The following is a description of a gene set: Sle2c1 is an NZM2410-derived lupus susceptibility locus that induces an expansion of the B1a cell compartment. B1a cells have a repertoire enriched for autoreactivity, and an expansion of this B cell subset occurs in several mouse models of lupus. Here we showed that expression of Sle2c1 enhances NZB cellular phenotypes that have been associated with autoimmune pathogenesis. A combination of genetic mapping and candidate gene analysis presents Cdkn2c, a gene encoding for cyclin kinase inhibitor p18INK4c (p18), as the top candidate gene for inducing the Slec2c1 associated expansion of B1a cells. A novel SNP in the Cdkn2c promoter is associated with a significantly reduced Cdkn2c expression in the splenic B cells and B1a cells from Sle2c1-carrying mice, which leads to defective G1 cell cycle arrest in splenic B cells and increased proliferation of Pc B1a cells. As cell cycle is differentially regulated in B1a and B2 cells, these results suggest that Cdkn2c play a critical role in B1a cell self renewal, and that its impaired expression leads to an accumulation of these cells with high autoreactive potential. Genes up-regulated in B lymphocytes from: peritoneal cavity versus spleen. species: Homo sapiens from publication Xu Z, Potula HH, Vallurupalli A, Perry D, Baker H, Croker BP, Dozmorov I, Morel L (PMID 21543644) Human Gene Set: GSE23114_PERITONEAL_CAVITY_B1A_BCELL_VS_SPLEEN_BCELL_UP, and this is the list of marker genes: THAP7, SEZ6, CNTNAP3, CLEC4E, MYBL2, EVA1A, ZNF503, RGS18, TMEM119, FGF2, PCP4, PTAFR (platelet activating factor receptor), SELENOO, POLH, PTX3, CATSPER2, GML, CYP8B1, UBQLNL, BICDL2, MAPKBP1, SPP1, CLDN19, GIMAP4, GAA, NUDT16-DT, VSTM2L, CPNE7, ZNF497, SLC19A1, USP22, BEST1, OR51B2, PTPN18, NOC2L, TIMP2, ZNF479, GJD2, SPATA24, CYTIP, MXD3, LMTK3, LUZP2, LINC-PINT, PIH1D1, TCTA, BARX1, WDFY2, SLC35E2B, ARL11, ARF1, KIR2DL5A, PFKFB3, GOLGA4-AS1, SNRPD3, WNT10A, PLCB2, PEX11G, GPRC5D, ADGRF5, GTF2B, FCGBP, MAD2L1BP, CHST5, PLK3 (polo like kinase 3), ASB14, RFPL1, GPR25, TRIM72, CNGA1, GPRASP1, MVD, SELPLG, MOCS3, SMG7-AS1, ACTL7A, CNTN2, AMN, LTBP3, EOGT, GRM7, LINC03124, ZNF341, PTPRJ, CRB2, P3H4, OR51B4, SRGAP3, GABRA3, ZFP2, DRD5 (dopamine receptor D5), IFITM3, E2F2, ERCC6L (ERCC excision repair 6 like, spindle assembly checkpoint helicase), CLDN3, FZD8, TMEM86A, TRAPPC14, DDX25, ZNF680, OR52K3P, SLC25A48-AS1, LINC03018, AP5B1, SPP2 (secreted phosphoprotein 2), MYO1A, CIMIP2B, SYNM, PIWIL2 (NCBI Gene Id 55124), GALM, TAAR5, ASB12, MAP2K5, CHMP1A, REC114, BMP6, CASP2, CDK5, B4GALNT2, WSB2, CLEC3B (NCBI Gene Id 7123), CTDSPL, MMP2, EGR1, PRDM15, PCP4L1, XAB2, KLHL40, KDM1A (NCBI Gene Id 23028), CALHM2, YWHAZ, CLU, ANGPT2, POSTN, GLT8D1, RNF11, CYP4Z2P, BTBD10, WFDC9, SYNGR1, ACTA2-AS1, F2RL2, LINC01242, GIP, SAA4, CHIT1, SULT1A2, IL31RA, CACNG4, ADAMTS20 (ADAM metallopeptidase with thrombospondin type 1 motif 20), VENTX, ZFPM1 (NCBI Gene Id 161884), PRDM1, PMP2, DBNDD1, IFT22, HEATR5A, STAP1, ANO2, CCN3, NR0B2, JRK, SLFNL1, KCNMB1, F9, GGN, PDCL, C14orf39, PPP4C, UBE2H, RPS6KA4, TRIM3, LRFN2, NPAS3, PTPRN, CD3D, LINC01270, CCNL1, SLC66A3, SEZ6L2, DNASE2B, ITGB2-AS1, WASF3, NES, NCS1, UMOD, SCPEP1, CIMAP2, JCHAIN, HMOX2